The following is a description of a gene set: studied in species Mus musculus Genes predicted to be targets of miRBase v22 microRNA mmu_miR_3089_3p in miRDB v6.0 with MirTarget v4 prediction scores > 80 (high confidence targets). from publication Chen Y, Wang X (PMID 31504780) Mouse Gene Set: MIR_3089_3P, and this is the list of marker genes: Tshz1, Dcc, Marchf1, Npl, Ifnk, Ebna1bp2 (NCBI Gene Id 97170), Ostc, Rxra, Eif4g3, Mapre2, Zfand5, Ncor1, Ino80, Slc7a7, Apol6, Sidt2, Rtl8a, Rad23b (NCBI Gene Id 78352), Kcng4, Card10, Kif26a, Zfp433, Ppp1r11, Csnk1g1, Nat8f2, Slk, Myo3b, Marcks, Pdcl, Rfx3, Eprs1, Tnks2, Adam17, Ark2n, Zfp747l1, Fam169a (NCBI Gene Id 320557), Svip, Rtl8b, Zdhhc15, Tmem101, Map3k1, Zfp704, Proser1, Arid4a, Sephs1, Zc3h12c, Vcpip1, Csrp3, Neurod6, Prkn, Atp9b, Ildr2, Klhdc10, Btaf1, Tsc1, Dpep1, Rasl11b, Rnf111 (NCBI Gene Id 93836), Nat8f4, Fbxl2, Septin3, Fam120c, Lemd3, Prkcb, Dcun1d2, Suz12 (SUZ12 polycomb repressive complex 2 subunit), Kcnn2, Cd44, Sncg, Stk32b (NCBI Gene Id 72191), Itgb3, Zfp760, Dnaja2, Ccl5, Cfap119, Dyrk1a, Rtl8c, Flrt2, Pax9 (paired box 9), Zfp280c, Shc4, Ube2r2, Lpgat1